Given this list of marker genes Pax8, Atp2b4, Styk1, Pdk3, Snx16, Nadk2, Gimap6, Psmf1, Kcnd2, Dnm3, Hs2st1, Dennd1b, Trmt10a, C2cd3, Gpsm3 (NCBI Gene Id 106512), Lrch2, Trpv1, Stx2, Lrrc8a, Csnk1g3, Esrrg, Tpk1, Diaph2, Atg4a, Snx5, Opa1, Zfp1008, Lrriq4, Casp7, Zfp488, Snrnp48, Lacc1, Vps37a, Ppp3cb (protein phosphatase 3, catalytic subunit, beta isoform), Timm21, Arhgdia, Lipt2, Masp2, Wnt5a, Gabra1, Vstm2a, Ctxn3, Pax6 (paired box 6), Cplx2, Cd207, Rpp40, Gimap7, Zfp746 (NCBI Gene Id 69228), Lypd6, Igsf11, Trip11, Ano7, Ube2h, Kif3b, Tbx20, Nbea (NCBI Gene Id 26422), Tnrc6a, Mrtfb, Rnf19a (ring finger protein 19A), Eprs1, Adam5, Zbtb44, Syne1, Cacybp, here is a description of the gene set: species: Mus musculus Mouse Gene Set: MIR_6910_3P Genes predicted to be targets of miRBase v22 microRNA mmu_miR_6910_3p in miRDB v6.0 with MirTarget v4 prediction scores > 80 (high confidence targets). from publication Chen Y, Wang X (PMID 31504780)